The following is a description of a gene set: Human Gene Set: GOBP_NUCLEAR_MEMBRANE_ORGANIZATION studied in species Homo sapiens A process that is carried out at the cellular level which results in the assembly, arrangement of constituent parts, or disassembly of the nuclear inner or outer membrane., and this is the list of marker genes: UBXN2A, UBE2I, TARDBP, CHMP2A, VPS4B, RCC1, CHMP5, PLK1, CHMP2B, ANKLE2, ATR, REEP4, CHMP1B, CHMP4A (charged multivesicular body protein 4A), NSFL1C (NCBI Gene Id 55968), LEMD2, VPS4A, CHMP3, CHMP4BP1, BROX, CDK1, SIRT2, LPIN1, NEK6, TOR1B, DCTN1 (NCBI Gene Id 82109), AKAP8L, CHMP4B, PAFAH1B1, CHMP4C, CTDNEP1, PRKCB, TOR1A, NEMP1, SPAST, TOR1AIP1, CHMP6, UBXN2B, REEP3, CHMP7, CHMP1A, VRK1, BANF1, PRKCA, TMEM43, GPER1, EMD